Given this list of marker genes Rbx1, Mta1, Lrrk2, Rbx1-ps, Sash1, Marchf7, here is a description of the gene set: Mouse Gene Set: GOBP_REGULATION_OF_PROTEIN_AUTOUBIQUITINATION Any process that modulates the frequency, rate or extent of protein autoubiquitination. studied in species Mus musculus